The following is a description of a gene set: Human Gene Set: GOMF_CERAMIDE_BINDING Binding to a ceramide, a class of lipids composed of sphingosine linked to a fatty acid. Ceramides are a major component of cell membranes. studied in species Homo sapiens, and this is the list of marker genes: PLTP, PLA2G4A, CERT1, GLTPD2 (glycolipid transfer protein domain containing 2), LAPTM4B, MAP1LC3B, PLEKHA8P1, VDAC2, PSAP, MAG, GLTP (NCBI Gene Id 51228), CLN8, CLIP3, CPTP (ceramide-1-phosphate transfer protein), VDAC1, PLEKHA8, EPDR1, CD300LF, RTN4R